Given this list of marker genes Xrcc1 (X-ray repair complementing defective repair in Chinese hamster cells 1), Cgas (NCBI Gene Id 214763), Htatsf1, Aplf, Parp2, Macroh2a1, Chd1l, here is a description of the gene set: Mouse Gene Set: GOMF_ADP_D_RIBOSE_MODIFICATION_DEPENDENT_PROTEIN_BINDING Binding to a protein upon ADP-ribosylation of the target protein. studied in species Mus musculus